Given this list of marker genes Man2a1, Zc3h6, Pcm1, Arl6, Herc1, Zfp120, Sp3 (trans-acting transcription factor 3), Sdcbp, Socs6, Mdm4, Ptprr, Gls, Pcca, 2510009E07Rik, Kras, Lgr4, Nin, Dner, Pdk3, Zbtb18, Zfp287, Slc6a11, Pds5b, Arid4a, Usf3, Mex3c, Kng1, Map4k5, Slc9a6, Tle3, Rwdd3, Mmp16 (NCBI Gene Id 56518), Mog, Rab6b, Jade1, Hnrnpa0, Slco1c1 (NCBI Gene Id 58807), Tex30, Pank3, Abhd17b, Xpo6, Cpne8, Prkaa1, Mctp1, Enc1, Ogn, Pspc1, Glrb, Tppp, Zc3h11a, Mat2b, Zfp275, Klf11, Eif4g2, Etl4, Man1a, Psd3, Myl12a, Ppp2r2a, Zfp207, Bltp3a, Zfand6, Dact1, Tbpl1, Kcna1, Uhrf2, Nts, Ero1a, Rab3c, Negr1, Ripk4, Lrrc58, Pcdh10, Tet1, Pigk, Ctnnb1, Zfhx4, Chrna7, Tmem170, Tle4, Hdac5 (NCBI Gene Id 15184), Mycn, Cdh9, Gpm6a, Slc39a9, Gpc5, P2ry10, Sephs1, Rtn4, Rab27b, Usp14, Grik2, Prrg3, Mbd5, Prkce, Creb1, Jazf1, Btbd10, Tgfbr1, Cggbp1, Mpped2, Zc3h10, Zkscan3, Stmn2, Entrep3, Ric8b, Zfand3, Lars2, Hs3st5, Tusc3, Hdac9, Ubqln2, Azin1, Ltb4r2, Cdyl2, Xpr1, Prlr, Meioc, Rfx3, Alg11, Plekha3, Ppp1r9a, Ctdspl2, Adss2, Kng2, Hycc2, Mplkip, Dusp16, Ube2h, Map2k4, Myt1l, Tnrc6b, Slc5a6, Rsrc1, Perm1, here is a description of the gene set: species: Mus musculus from publication Chen Y, Wang X (PMID 31504780) Mouse Gene Set: MIR_6920_5P Genes predicted to be targets of miRBase v22 microRNA mmu_miR_6920_5p in miRDB v6.0 with MirTarget v4 prediction scores > 80 (high confidence targets).